Given this list of marker genes Slc24a3, Myom3, Sgca, Gm9947, Casq2, Igdcc4, Fgf9, Fgfr4, Macrod1, Actn3, Iffo1, Prkag3, Neurl1a, Gm42875, Srpx2, Rfx8, Atp2a1, Gjd4, Sytl2, Mstn, Klhl41, Chrnb1, Ptgis (prostaglandin I2 (prostacyclin) synthase), Acoxl, Tpm2, Fitm1, Gramd1b, Klhl40, Chrng, C1qtnf3, Chrna1, Mylpf, Nes, Platr14, Cacng1, 4930481A15Rik, Tex16, Mybpc1, Vgll3, Edn3, Frmpd1os, Ky, Fbxw10, Sh3glb1, 7530428D23Rik, Mymk, Mamstr, Rapsn, Pitx3, Spg21, Rnf217, Stc1, Col19a1, Parm1, Gm30735, Flnc, Itgb6, Fap, Mylk4, 4632404M16Rik, Ppfia4, Nrk, Gm8091, Cep41, Cdh15, Frmpd1, Ncoa1 (nuclear receptor coactivator 1), Musk, Mybph, Cdkn1c, Myh3, Ano5, Ryr1, Cspg4b, Neb, Myl1, Pgf (NCBI Gene Id 18654), Best3, Ablim3, Fgf5, Vgll2, 1700109K24Rik, Prss36 (serine protease 36), Olfml2b, Tnnt1, Chrnd, Ndst4, Grep1, Pitx2, Tnnt3, Myod1, Kcne5, Itm2a, Fndc5, Hjv (hemojuvelin BMP co-receptor), Tmem38a, Rgs16, Capn6, Pax7, Clcn5, Tnnc2, Mymx, Dync1i1, Sgcg, Myf5, Art1, Ssc5d, Il17b, Sync, Myog, Tceal7, Myom2, Cdkn1a, Sema6b, Shisal2a, Pgm5, Myh8, Chrm3, Mrln, Hs6st2, Shisa2, Mypn, Pgpep1l, Aknad1, Eya4, Gm30015, 1110002E22Rik, Slf2, 9330175M20Rik, 5730419F03Rik, Adora1, Septin4, A430078I02Rik, Awat2 (acyl-CoA wax alcohol acyltransferase 2), 4930544I03Rik, Fbxo17, Cd82, Cacna1s, Lincmd1, Msc, Myot, Stac3, Adh1, Lmod3, here is a description of the gene set: Mouse Gene Set: DESCARTES_ORGANOGENESIS_MYOCYTES from publication Cao J, Spielmann M, Qiu X, Huang X, Ibrahim DM, Hill AJ, Zhang F, Mundlos S, Christiansen L, Steemers FJ, Trapnell C, Shendure J (PMID 30787437) Mouse Organogenesis Cell Atlas (MOCA) DE_gene_main_cluster.csv, fold.change>=1.5, qval<0.05, pval<0.05 studied in species Mus musculus